Given this list of marker genes SLC15A3, GRB2, MITD1 (microtubule interacting and trafficking domain containing 1), RMDN3, OCIAD1, DPCD, MSR1, B3GNT3, TAFAZZIN, INA, RBM18, GALNS, CSK, MAP4K5, SELENOP, CLEC4A, RGS10, SDC3, SLF2, NUDT13 (NCBI Gene Id 51055), HLA-E, CD47, IFIH1, AGFG1, STAG2 (STAG2 cohesin complex component), CPSF4L, ASPH, ERGIC2, GPR137B, IKZF1, COPS8, TSEN15, PDZD11 (PDZ domain containing 11), SRD5A3, TMEM140, SLC31A2, SCRN2, DPYSL4, RSL1D1, PRRG2, GTF2A1, RPL7L1, IMP4, C1QC (NCBI Gene Id 90369, complement C1q C chain), SKAP2, MAP7D1, CTSV, SERTAD1, LAPTM4A, SAE1, NMI, TOR3A, UBA7, PRKCA, C1QB, ZFAND2A, IFT22, CXXC5, KRAS, BST1, OLFML3, HOXD11, SOCS4, SAFB, MOB2, TMEM183A, VAMP4, SLC6A8, KAT6A, LMO2, PARP9, ATP6V1B2, TMEM209, USB1, KATNA1, VNN1 (vanin 1), PSME1, STRN, SMAGP, AGTPBP1 (ATP/GTP binding carboxypeptidase 1), KLK7, ATMIN, CLIP2, SLF1, TIMM44, JPT1, SRPRA, PRMT7, CLASP2, C19orf25, UBE2G1, CCR5, PRDX2, SLC28A2, ERGIC1, FAM114A2, PSMB2, RNF149, POMP (NCBI Gene Id 51371), SGF29 (NCBI Gene Id 112869), UTP18, GJD2, PSMC4, TMBIM1, PIM2, ARID5A (NCBI Gene Id 10865), SNX2, ZBTB18, ATE1, RBM6, DHRS1, MET, ZBTB33, MICU1 (mitochondrial calcium uptake 1), WDR86, ABI1, KDR, HELZ2, SAP30, RAP1B, PAFAH1B1, POPDC2, TCF7L2, TARDBP, ZNF227, TRIP10, DYNLL1, TMLHE, BLVRA, PTTG1, TAS1R1, CNBP, ANAPC16, AOC1, KIF5B, USP20, RAP2C, ATF6, ARFGAP3, TTC1, RARS1, PNPO, AKR1E2, CTSK, TREX1, ZNF18, SPIB, RNH1, R3HCC1, ARHGEF28, SELENOS, MCM6, FOS, IFI35, LPXN, SEPTIN7 (NCBI Gene Id 989), SLIT3, NUBP2, DCLRE1A, PSME4, PLD4 (phospholipase D family member 4), TIMM50, NUDT4 (nudix hydrolase 4), SLC25A26, FKBP3, KRT15, TYSND1, ENPP2 (ectonucleotide pyrophosphatase/phosphodiesterase 2), RFC3, ASPN, THAP2, BFSP1, MRPL13, RRP8 (NCBI Gene Id 23378), TOR1AIP1, UAP1L1, MVB12A, SMARCE1, CCR2, ISG15 (NCBI Gene Id 9636), NCK2, APOBEC1, PSEN2, TADA1, FUT8, DHX58, MLLT3, CEPT1, IL18BP, GABRA1, MCM10, CYP17A1, UQCC1, AFTPH, EFNB2, RHOC, MYL11, SCPEP1, TCAP, ISG20, here is a description of the gene set: from publication Amit I, Garber M, Chevrier N, Leite AP, Donner Y, Eisenhaure T, Guttman M, Grenier JK, Li W, Zuk O, Schubert LA, Birditt B, Shay T, Goren A, Zhang X, Smith Z, Deering R, McDonald RC, Cabili M, Bernstein BE, Rinn JL, Meissner A, Root DE, Hacohen N, Regev A (PMID 19729616) Genes down-regulated in comparison of dendritic cells (DC) stimulated with Pam3Csk4 (TLR1/2 agonist) at 16 h versus DC cells stimulated with Gardiquimod (TLR7 agonist) at 16 h. studied in species Homo sapiens mouse primary BMDCs were stimulated with tlr ligands and gene expression changes were profiled on Affymetrix arrays Human Gene Set: GSE17721_PAM3CSK4_VS_GADIQUIMOD_16H_BMDC_DN